Given this list of marker genes DVL2 (dishevelled segment polarity protein 2), DVL1, CSNK2B, PIP5K1B, CSNK2A2, DVL3, CSNK1E, CSNK2A1, here is a description of the gene set: studied in species Homo sapiens WNT mediated activation of DVL Human Gene Set: REACTOME_WNT_MEDIATED_ACTIVATION_OF_DVL